The following is a description of a gene set: part of: Metabolism of amino acids and derivatives studied in species Homo sapiens These reactions mediate the synthesis of aspartate and asparagine from glutamate, TCA cycle intermediates, and ammonia and and allow the utilization of carbon atoms from these amino acids for glucose synthesis under fasting conditions. Reactome Pathway: Aspartate and asparagine metabolism, and this is the list of marker genes: NAALAD2, ASPG, SLC25A13, FOLH1B, GADL1, GOT1, FOLH1, ASPA, ASNS, SLC25A12, GOT2, NAT8L